The following is a description of a gene set: Catalysis of the activation of small proteins, such as ubiquitin or ubiquitin-like proteins, through the formation of an ATP-dependent high-energy thiolester bond. Mouse Gene Set: GOMF_UBIQUITIN_LIKE_MODIFIER_ACTIVATING_ENZYME_ACTIVITY species: Mus musculus, and this is the list of marker genes: Mocs3, Uba6, Sae1, Uba1y, Uba5, Uba3, Uba7, Nae1, Atg7, Uba2, Uba1